The following is a description of a gene set: The series of molecular signals initiated by a ligand binding to toll-like receptor 2. Human Gene Set: GOBP_TOLL_LIKE_RECEPTOR_2_SIGNALING_PATHWAY species: Homo sapiens, and this is the list of marker genes: RIPK2, F2RL1, PIK3AP1, TLR2, ACOD1 (NCBI Gene Id 730803), HMGB1, IRAK1, TLR6, MFHAS1, TNFAIP3, CYBA, PJA2, LGALS9, TNIP2, TREM2, LYN, TLR1, TIRAP